The following is a description of a gene set: species: Homo sapiens Formation of intermediate mesoderm Human Gene Set: REACTOME_FORMATION_OF_INTERMEDIATE_MESODERM, and this is the list of marker genes: PAX8, FGF2, LHX1, FOXC1, OSR1, FOXC2, PAX2, BMP4